Given this list of marker genes GABPA, MEF2C, H4C1, SCIN, RAB7B, H4C16, FAXDC2, MYB, LOX, H4C3, H4C13, H4C4, H4C12, RCOR1, CNOT4, H4C2, RBM15, PF4, PRMT1, H4C6, TESC, H4C11, H4C14 (H4 clustered histone 14), ZNF16, GATA2, THPO, L3MBTL1, H4C15, EIF6, MTURN, PRMT6, HMGB2, H4C5, MIR486-1, H4C8, CIB1, PITHD1, H4C9, here is a description of the gene set: studied in species Homo sapiens Human Gene Set: GOBP_REGULATION_OF_MEGAKARYOCYTE_DIFFERENTIATION Any process that modulates the frequency, rate or extent of megakaryocyte differentiation.